Given this list of marker genes DCAF7 (DDB1 and CUL4 associated factor 7), ATF5, MYO1F, KLF13, TFEB, UBAC1, PUM2, HDGF, USP22, NUP214, HECA, TNFAIP8L1, CRTC3, SASH3, ZNF217, RIN3, DENND11, VIRMA, CTCF, TLR1, PSMG2, ARPC1B, NAGS, POLR2B, GDE1, GIMAP8, PHAF1, FGD3, MARF1 (NCBI Gene Id 9665), GABARAP, CREBL2, CTNND1, KIF3B, LILRB2, KDM3B, DAPP1, PTPRJ, CSK (C-terminal Src kinase), ZNF106, NCKAP1L, PIP5K1C, ZFP36L2, MKRN1, BMF, CEP350, JKAMP, TNFAIP2, NLRC4, SMARCAL1, TGFBR2, FBXO42, CAB39 (calcium binding protein 39), ANKRD13A, LACC1, KIAA2013, AP2M1, KMT2A, ARRB1, DCAF5, FHOD1, AMPD2, SYNE3 (NCBI Gene Id 79686), ELF2, DAGLB, SMAP2, IL10RA, TBC1D2B, CCR2, RGS19, SETD1B, SNX20, PTTG1IP, CHAMP1 (NCBI Gene Id 84453), FOXK1 (forkhead box K1), CFP, NBR1, ZDHHC7, CBL, BOD1L1, STX6, LILRB3, SYK, WIPI2, SPG21, CDIPT, BCOR, MAP7D1, GLTP, RNF38, LILRB1, SEMA4B, TACC1, NUP62, PRELID1, FAM220A, CALHM2, ACOX1, PAGR1, MRTFA, UBE2W, CHD8 (chromodomain helicase DNA binding protein 8), PIK3CD, DPP8, SRSF9, ELOVL1 (NCBI Gene Id 96722), SIN3A, RCOR3, POU2F2, CMTM3, PHIP, GRB2, PHF23, POLDIP3, GLE1, NCOR1, DCAF12, PTAFR, CSF1R, ILK, TOR1A, ZNF710, RTCB, PARP1, APOBR, TRAPPC12, PAFAH1B2, ZNF740, GNB2, TAF5, FRAT1, TRIM8, NCOA4, MLXIP, RNF44, TWF2, FOXN3, NCOA6, IKBKE, RAB8A, STK38, ARRDC2, CCM2, TNRC18, APMAP, RASSF2 (NCBI Gene Id 9770), TCF20, EVI2A, CMKLR1, MAP3K14, FAM89B, HCK, ARID1A, NT5DC2, FRMD8, DUSP7, CTDSP2, MAT2B, SIPA1, MAVS, KDM5A, UBN2, RRM2B, RPS6KA1, ENG, WBP1L, ARL6IP5, IFFO1, DDX17, CD14, IFNAR1, ARHGAP1, MAPK14, RETREG3, ZBTB44, TCEANC2, ZFTA, ORAI2, BRD3, PLXNB2, PHC2, MAML1, PINK1, MIDEAS, BCL9L, MOB3A, SMAD3, GAPT, USP3, THEMIS2, GRK3, RICTOR, ARF3, FUCA1, RHOG, MPEG1, DHX16, PAIP2, GIT2, ST8SIA4, MAST3, here is a description of the gene set: from publication Dower K, Ellis DK, Saraf K, Jelinsky SA, Lin LL (PMID 18292579) TREM-1 is an orphan immunoreceptor expressed on monocytes, macrophages, and neutrophils. TREM-1 associates with and signals via the adapter protein DAP12/TYROBP, which contains an immunoreceptor tyrosine-based activation motif (ITAM). TREM-1 activation by receptor cross-linking is pro-inflammatory, and can amplify cellular responses to Toll-like receptor (TLR) ligands such as bacterial lipopolysaccharide (LPS). To investigate the cellular consequences of TREM-1 activation, we have characterized global gene expression changes in human monocytes in response to TREM-1 cross-linking in comparison to and combined with LPS. Both TREM-1 activation and LPS up-regulate chemokines, cytokines, matrix metalloproteases, and PTGS/COX2, consistent with a core inflammatory response. However, other immunomodulatory factors are selectively induced, including SPP1 and CSF1 (i.e., M-CSF) by TREM-1 activation and IL-23 and CSF3 (i.e., G-CSF) by LPS. Additionally, cross-talk between TREM-1 activation and LPS occurs on multiple levels. While synergy in GM-CSF protein production is reflected in commensurate mRNA abundance, comparable synergy in IL-1b protein production is not. TREM-1 activation also attenuates the induction of some LPS target genes, including those that encode IL-12 cytokine family subunits. Whereas positive TREM-1 outputs are abolished by the PI3K inhibitor wortmannin, this attenuation is largely PI3K-independent. These experiments provide a detailed analysis of the cellular consequences of TREM-1 activation, and highlight some of the complexity in signal integration between ITAM- and TLR-mediated signaling. Genes down-regulated in comparison of monocytes treated with anti-TREM1 versus monocytes treated with control IgG. species: Homo sapiens Human Gene Set: GSE9988_ANTI_TREM1_VS_CTRL_TREATED_MONOCYTES_DN